Given this list of marker genes GABRG2, NLGN2, GABRA3, CNR2, NRXN1, PLCL1, BEST1, GABRB2, GABRA6, SYN3, ALDH5A1, ZDHHC12, ADRA1A, CLN3, PHF24, NPY5R, GABRA4, TACR1, VPS54, PRKCE, ADORA2A, GABRA2, DRD2, NPAS4, NPS, RAC3, SLC38A1, CNTNAP4, GABRB3, GABRA1, TPBG, GABRD, GABBR2, GABRG1 (gamma-aminobutyric acid type A receptor subunit gamma1), NALCN, SLITRK3, GABBR1, GABRE, KIF5B, CA7, KCNK2, HAP1, TAC1, CA2, HAPLN4, GABRA5, RAC1, NF1, NLGN1, KRAS, BAIAP3, ADORA1, EZH2, STXBP1, CLCN3, ZDHHC3, GABRG3, PLCL2, USP46, CLSTN3, here is a description of the gene set: species: Homo sapiens Human Gene Set: GOBP_SYNAPTIC_TRANSMISSION_GABAERGIC The vesicular release of gamma-aminobutyric acid (GABA). from a presynapse, across a chemical synapse, the subsequent activation of GABA receptors at the postsynapse of a target cell (neuron, muscle, or secretory cell) and the effects of this activation on the postsynaptic membrane potential and ionic composition of the postsynaptic cytosol. This process encompasses both spontaneous and evoked release of neurotransmitter and all parts of synaptic vesicle exocytosis. Evoked transmission starts with the arrival of an action potential at the presynapse.